The following is a description of a gene set: species: Mus musculus Mouse Gene Set: WP_APOE_AND_MIR146_IN_INFLAMMATION_AND_ATHEROSCLEROSIS ApoE and miR-146 in inflammation and atherosclerosis, and this is the list of marker genes: Tlr2, Apoe, Rela, Nfkb2, Irak1, Tlr4, Spi1, Traf6 (TNF receptor-associated factor 6)